The following is a description of a gene set: species: Homo sapiens Human Gene Set: E2F_Q6_01 Genes having at least one occurrence of the motif NKCGCGCSAAAN in the regions spanning 4 kb centered on their transcription starting sites. This matches the E2F, TFDP1 transcription factor binding site V$E2F_Q6_01 (v7.4 TRANSFAC)., and this is the list of marker genes: MELK, CACNA1G, ARHGAP36, DNMT1, STAG2, PKMYT1, DCTPP1, JADE1, HMGN2, BCOR, KLF5, CDC25A, PODN, PRIM1, DCK, FMO4, BRMS1L, GPAT2, ARID4A, PRMT3, AGFG2, ZCCHC8, GAPDH, PTMA (prothymosin alpha), PEG3, CTNND2, ARHGAP11A, DAXX, HNRNPA1 (heterogeneous nuclear ribonucleoprotein A1), PAN2, UCHL1, PCSK4, SMC1A, TNPO2, KCND2, EVA1B, RRM2, POLA1, DDX17, MCM2, RAD51, IPO7, CDC6, RBL1, ZBTB8OS, SSU72, BMP7, WEE1, PPP1R9B, TIAM1, STT3B, SALL1, ATE1, CASP8AP2, RPS19, FBXL20, MAZ, E2F7, DLL4, ANKHD1, MCM6, SEMA5A, POLH (NCBI Gene Id 5429), HOXA9, JADE2, RND2, DMD, RAB11B, UFD1, ERBIN, SRSF2, DOLK, MAP3K13, KLHDC3, MEA1, PPM1J, ORC1, ZDHHC17, BARHL1, RANBP1, EZH2, NRP2, MTF2, DMRT1, HNRNPD, ATAD2, NUTF2, POLD1 (DNA polymerase delta 1, catalytic subunit), TRMT2A, TOPBP1 (NCBI Gene Id 11073), CLPTM1, E2F3, NKX2-2 (NCBI Gene Id 4821), CDKN1A, PCIF1, TMEM131L, OSBPL7, TBX3 (T-box transcription factor 3), NHLRC2, LUC7L2, MXD3, INTS7, SFMBT1, MAT2A, PPM1D (protein phosphatase, Mg2+/Mn2+ dependent 1D), FBXO5, DPYSL2, GMNN, ZNF687, GRIA4, TLE3, C14orf119, SYPL1, CDC20B, REPS2, CDC45, ZNF565, DNAJC5G, H1-3, ADGRB1, CSRNP1, BTBD10, CPSF7, SLC6A4, PCDH7, TMEM256, NIPBL, NSD3, CTDSPL2, DDB2, ANKHD1-EIF4EBP3, RCOR2, DNAJC11, PTCHD1, DLEU2, SORBS1, AP4M1, OVOL2, FLI1 (NCBI Gene Id 2313), ZNF362, HTR2C, PDS5B, SMC3, DLEU1, STMN1, KMT5A, RMI2, TIPIN, POLE2, MCM4, SDHAF2, IER5L, TMEM187, PRPF38A (pre-mRNA processing factor 38A), KLHL35, DUSP7, ACIN1, RFC1, FANCG, CITED2, MSI1, SRSF1, DLST, MARCKSL1, ODAD3, PLK4, PUF60, SASS6, FAM120C, STAG1, PCLAF, RBPJ, RALY, LRRC56, FANCL, FHIP1B, TUBA3E, RBBP4, NECTIN1, GLRA3, LIG1, CNPY2, DUSP6, PCNA, XPO5, ACBD6, RPS6KA5, MCM3, CDCA7, SIK2, KCNA6, CCN1, ZNF367 (zinc finger protein 367), ZMYM2, H2AZ1, SERBP1, GPRC5B, STX5, ZIM2, ETV4, ID3, UNG, EIF5A, SUV39H1, CBX5, SNCB, MCM7, SLC16A2, TRIR, H2BC10, CASP2, YWHAQ, ANP32E, EIF1AX, NCL, PCYT2, ERG, CNBP, MYC, PAQR4, NASP, PRKCSH, ZSWIM9, USP49, E2F1, EPHB1, SREK1, SLITRK3, TRMT13, E2F8, RIBC1, KPNB1, NDUFA11, SMG1, ADAMTS2, PRKDC, SLITRK4, SMC2 (structural maintenance of chromosomes 2), CTCF, ADAMTS9, TSC22D2 (NCBI Gene Id 9819), DCLRE1A